Given this list of marker genes CSNK2B, PER3, CRY1, PER2, CRY2, CSNK1E, PPP1CC, PER1, CSNK2A2, PPP1CA, CSNK2A1, CSNK1D, PPP1CB, CDK5 (cyclin dependent kinase 5), here is a description of the gene set: Reactome Pathway: Phosphorylation and nuclear translocation of the CRY:PER:kinase complex part of: Circadian clock Cryptochrome proteins (CRY1, CRY2) and Period proteins (PER1, PER2, PER3) are translated in the cytosol. CDK5 phosphoryates PER2 in the cytosol and phosphorylated PER2 interacts with CRY1 (inferred from mouse homologs in Brenna et al. 2019). The heterodimer associates with kinases Casein kinase I delta (CSNK1D) and Casein kinase I epsilon (CSNK1E) and other CRY and PER proteins in a large complex in the cytosol (inferred from mouse homologs in Nangle et al. 2014, Aryal et al. 2017) and the CRY and PER proteins are phosphorylated by CSNK1D and CSNK1E. The large complex containing the phosphorylated CRY and PER proteins is then translocated into the nucleus (inferred from mouse homologs in Kume et al. 1999, Vielhaber et al. 2000, Aryal et al. 2017, Cao et al. 2023), though there is a discrepancy in the measured sizes of the nuclear complex. Cao et al. (2023) used gel exclusion chromatography and glycerol gradient centrifugation and found a mass of 707 kDa: Aryal et al. (2017) used a novel electrophoretic method and found a mass of 1.9 MDa. The large CRY:PER:kinase complex then associates with phosphorylated BMAL1:CLOCK heterodimers (and likely with BMAL1:NPAS2 heterodimers) and represses the transactivation activity of BMAL1:CLOCK (inferred from mouse homologs in Griffin et al. 1999, Ye et al. 2014, Chiou et al. 2016, Cao et al. 2021). studied in species Homo sapiens